The following is a description of a gene set: from publication Bedogni F, Hevner RF (PMID 34321999) Mouse Gene Set: HEVNER_TELENCEPHALON_ERYTHROCYTES studied in species Mus musculus Genes selectively expressed by erythrocytes (red blood cells) in embryonic day 14.5 mouse telencephalon., and this is the list of marker genes: Hbb-bh1, Hba-x, Alas2 (aminolevulinic acid synthase 2, erythroid), Hbb-bs, Car2, Hbb-y, Ahsp, Slc4a1